Given this list of marker genes Atf6, Bok, Bak1, Pik3r1, Ern1, Ptpn2, Tmem33, Bax, Agr2, Xbp1, here is a description of the gene set: species: Mus musculus Mouse Gene Set: GOBP_POSITIVE_REGULATION_OF_ENDOPLASMIC_RETICULUM_UNFOLDED_PROTEIN_RESPONSE Any process that activates or increases the frequency, rate or extent of endoplasmic reticulum unfolded protein response.